The following is a description of a gene set: from publication Foster CT, Dovey OM, Lezina L, Luo JL, Gant TW, Barlev N, Bradley A, Cowley SM (PMID 20713442) Genes up-regulated in ES cells (embryonic stem) heterozygotic for KDM1A loss of function mutant compared to the homozygotic loss of the gene. species: Mus musculus Mouse Gene Set: FOSTER_KDM1A_TARGETS_UP Lysine-specific demethylase 1 (LSD1), which demethylates mono- and dimethylated histone H3-Lys4 as part of a complex including CoREST and histone deacetylases (HDACs), is essential for embryonic development in the mouse beyond embryonic day 6.5 (e6.5). To determine the role of LSD1 during this early period of embryogenesis, we have generated loss-of-function gene trap mice and conditional knockout embryonic stem (ES) cells. Analysis of postimplantation gene trap embryos revealed that LSD1 expression, and therefore function, is restricted to the epiblast. Conditional deletion of LSD1 in mouse ES cells, the in vitro counterpart of the epiblast, revealed a reduction in CoREST protein and associated HDAC activity, resulting in a global increase in histone H3-Lys56 acetylation, but not H3-Lys4 methylation. Despite this biochemical perturbation, ES cells with LSD1 deleted proliferate normally and retain stem cell characteristics. Loss of LSD1 causes the aberrant expression of genes, including those coding for transcription factors with roles in anterior/posterior patterning and limb development, such as brachyury, Hoxb7, Hoxd8, and retinoic acid receptor γ (RARγ). The gene coding for brachyury, a key regulator of mesodermal differentiation, is a direct target gene of LSD1 and is overexpressed in e6.5 Lsd1 gene trap embryos. Thus, LSD1 regulates the expression and appropriate timing of key developmental regulators, as part of the LSD1/CoREST/HDAC complex, during early embryonic development., and this is the list of marker genes: Dpysl3, Idh1, Mdfic, Srd5a2, Magea13, Acp3, Map2, Cela1, Ttc39c, Klk1b5, AW551984, Best1, Ly6g6e, Tst, Myom2 (myomesin 2), Rbm47, Mgst2, Tspan2, Taf9b, Abcc5, Kiss1, Mycl, Magea5, Prickle1, Abca14, Gca (NCBI Gene Id 99021), Tph2, Pla1a, Hsh2d, Oc90, Uroc1, Ctsa, Agrp, Klk1, Aim2, Msantd5l, 4930524B15Rik, Mt3, Ptpn22, Aqp9, Krt23, Nin, Sytl3, Gmpr, Igbp1b, Fzd10os, Dusp26, Pof1b, Ezhip, Klk1b4, Slc30a3, Hsf3, Boll, C8b, Obox6, Cct6b, Cfap206, Cox7a1, Fxyd5, Rhox4d, Gtsf1l, Dcstamp, Calcoco2, Sapcd1 (NCBI Gene Id 78376), Mansc1, Syt5, Alg14, Dync1i1, Clps, Mgarp, Pwwp4a, Mboat1, Tnni2, Gm15107, Xlr4a, Klk13, Gpha2, Ppp2r2c, Ly6a, Tpbg (trophoblast glycoprotein), Mmp2, Cd3d, Usp29, Klk10, Ifi27, Itsn1, Defa3, Zscan5b, Copz2, Tex13b, H2-Ab1, Rbms2, Tulp4, Minar2, Selplg, Erich6, Ank2, Lrcol1, Rragd, Cdc42ep5, Magea4, Gpr143, Myom3, Aass, Cela2a, Alox5ap, 4930591A17Rik, Crybg1, Pga5, Pwwp4b, Nrg4, T, Pkd2l1, Brdt, Oas1g, Clic6, Actn2, Diras2, Mx2, Taf1d, Cxcl14, Padi6, Chi3l1, Cd74, Klf17, Acot1 (acyl-CoA thioesterase 1), H2-Eb1, Slc6a13, Klk1b26, Gstm5, Tmem40, Xlr5a, Ldaf1, Sftpd, Slc15a2, Fhl1, Pcolce2, Rnf170, Gpr137b, ENSMUSG00000141259, Pramel30, Gm7247, Map1lc3a, Cda, Tekt1, Ccl25, Slc16a9, Clcnkb, Hspb8, Nlrp4c, Tsx, Matcap2 (microtubule associated tyrosine carboxypeptidase 2), Magea8, H6pd, Stk32a, Cpn1, Kcnu1, Ovol2 (ovo like zinc finger 2), Fmr1nb, Lpl, Tnnt1, Gstm6, Akr1c18, Magea10, Ntrk2, Magea2, Sult2b1, Gm773, Clca1, Fam25a, Agmat, Fetub, Mllt3, Atg10, Pdlim4, Cd200, Acss1, Itgae, 2010204K13Rik, Fgl1 (fibrinogen-like protein 1), Gsta3, Pbld2, Prx, Bpifb5, Crygs, Slc4a5, Qpct, Ly6e, Timm8a2, Cyp2j9, Aox3, Lpar1, Pramel7, App, Htatip2, Slc5a4a, Thy1, Barx2, Rasgrp3, 4933412E12Rik, Sh3rf2, Ube2l6, Cyp2c55, Bbs7, Slc36a3 (NCBI Gene Id 215332), Cpne9, Nckap1l, Cyp2c23, Omt2b, Slamf9, Mogat2, Saxo1, Them5, Xk, Defb42, Otog, Defb30, Kyat1, Gjb4, Bfsp2, Sash1, Pde6a, Zc4h2, 4930486L24Rik, Bahd1, Crabp1, Selenop, L3mbtl3, Reg1, Echdc2, Lyzl4, Cdkn1a, Grep1, Sult6b2, Tex19.2, Tuba3a, Ifitm1, Npw, Slc26a4, Elovl4, Hoxb7, Popdc3, Mt1, Rcsd1, Slc5a4b, Mbl2, Col2a1, Adgrf3, Trpv2 (transient receptor potential cation channel, subfamily V, member 2), Adh4, Snca, Bcas1, Brcc3dc, Rims1, Pramel14, Impdh1, Scml2, Crxos, Tspan8, Crygd (NCBI Gene Id 27311), Cntnap2, Spink2, Ebi3, Xpnpep2, Mfsd4b1, Rnf182, Nat2, Sptbn2, Mup2, Myl2, Ddr2, Smtnl1, Spic (Spi-C transcription factor (Spi-1/PU.1 related)), Reln, Akr1cl, Hecw2, Ncmap, Mup6, Cabs1, Cdh3, Ccdc172, Plac8, Pnlip, Plxdc1 (plexin domain containing 1), Liph, Tmem62 (NCBI Gene Id 96957), Dnajc5g, Klk1b27, Hebp2, Pmel, Fam3b, Lgals3bp, Gtsf1, Hoxd8, Myl4, Cpne2, Ccdc169 (NCBI Gene Id 320604), Ott, Tnfrsf17